The following is a description of a gene set: Genes predicted to be targets of miRBase v22 microRNA hsa-miR-146b-3p in miRDB v6.0 with MirTarget v4 prediction scores > 80 (high confidence targets). Human Gene Set: MIR146B_3P species: Homo sapiens from publication Chen Y, Wang X (PMID 31504780), and this is the list of marker genes: C1S, CHD1, ASTN1, SENP1, NCK2, ABCA9, TMEM260, HSPA4L, SERINC5, B3GLCT, CELF2, ITSN1, STAP1, UBE2QL1, SOS1, TAP2, SLC20A1, RGL1, BMAL2, LOXL1, RASL10B, PRDM6, SMPD3, PRRX1, SHISA7, CTNNA1, UNC5C, ADGRF2P, RGS20, MLLT11, ZBTB8A, ZNF37A, CHL1, BSND, SLC26A9, DIPK2A, NLRP7, TMEM178B, LINC03040, ELF4, MATCAP2, SNX30, ABCG4, SEPHS2, ZFAT, SOX11, DDX3X, KIF1B, PRKRIP1, CYB561D1, CSMD1, TULP3, GTF2H1, PAK6, KDM3B, VSTM4, EFNB2, ZNRF2, PLCXD2, PPP6C, STX17, PANK4, FEZ1, SCG3, HSPA14, LCN1, ADARB2, BACH2, EPHB3, KBTBD2, TPPP